Given this list of marker genes IER3 (immediate early response 3), PSMD11, TK1, MAGEA6, CD9, JUND, STIP1, CCND1, TRAM2, TOM1 (NCBI Gene Id 10043), GPRC5A (G protein-coupled receptor class C group 5 member A), TSPAN8, PTPRN, MAGEA1, MAGEA3, MLF2, MALL, DUSP14, NCOR1, CDK2AP2, HRAS, GDF15, FERMT2, here is a description of the gene set: Human Gene Set: HOFMANN_MYELODYSPLASTIC_SYNDROM_RISK_UP Gene patterns of expression in purified CD34(+) bone marrow cells from 7 patients with low-risk myelodysplastic syndrome (MDS) and 4 patients with high-risk MDS were compared with expression data from CD34(+) bone marrow cells from 4 healthy control subjects. CD34(+) cells were isolated by magnetic cell separation, and high-density oligonucleotide microarray analysis was performed. For confirmation, the expression of selected genes was analyzed by real-time polymerase chain reaction. Class membership prediction analysis selected genes. Using the expression profile of these genes, we were able to discriminate patients with low-risk from patients with high-risk MDS and both patient groups from the control group by hierarchical clustering (Spearman confidence). The power of these genes was verified by applying the algorithm to an unknown test set containing expression data from 8 additional patients with MDS (3 at low risk, 5 at high risk). Patients at low risk could be distinguished from those at high risk by clustering analysis. In low-risk MDS, we found that the retinoic-acid-induced gene (RAI3), the radiation-inducible, immediate-early response gene (IEX1), and the stress-induced phosphoprotein 1 (STIP1) were down-regulated. These data suggest that CD34(+) cells from patients with low-risk MDS lack defensive proteins, resulting in their susceptibility to cell damage. In summary, we propose that gene expression profiling may have clinical relevance for risk evaluation in MDS at the time of initial diagnosis. Furthermore, this study provides evidence that in MDS, hematopoietic stem cells accumulate defects that prevent normal hematopoiesis. Genes up-regulated in bone marrow hematopoietic stem cells (HSC, CD34+) from patients with high risk of myelodysplastic syndrom (MDS) compared to the low risk patients. species: Homo sapiens from publication Hofmann WK, de Vos S, Komor M, Hoelzer D, Wachsman W, Koeffler HP (PMID 12411319)